Given this list of marker genes DPP10, ASB8, TNRC6B, XKR4, NECAB2, PROX1, PCDHB9, KALRN, CIT, TMEM45A, ARNT2, POLR1D, LRRTM3, RALBP1, WASL, ATP2A2, C5orf67, EP300, ANKRD10, PEG10, ITSN1, PDXDC1, BABAM2, POLG, SNX3, SCAI, OTOGL, SLC9A2, DYNC1I1, XIRP2, MAP3K20, KLHL25, NAA50, CSDE1, TRANK1, KDM4A, AFF2, PSMA4, PLPPR4, CAMSAP2, NELL2, LPIN2, GARIN6, E2F3, THNSL1, CRADD, CXADR, TMEM165, ZFAND6, PHTF2, here is a description of the gene set: species: Homo sapiens Genes predicted to be targets of miRBase v22 microRNA hsa-miR-3130-3p in miRDB v6.0 with MirTarget v4 prediction scores > 80 (high confidence targets). from publication Chen Y, Wang X (PMID 31504780) Human Gene Set: MIR3130_3P